Given this list of marker genes SFRP2, PCOLCE, MFAP4, IGFBP5, LHFPL6 (NCBI Gene Id 10186), MGP, GPC3, PI15, IL11RA, MEOX2, RCN3, ITM2A, FLRT2, CDH9, RAB23, GPX7, LRRC17, PRAF2, RAMP2, CD248, CUEDC2, PLAC9, here is a description of the gene set: from publication Gao S, Yan L, Wang R, Li J, Yong J, Zhou X, Wei Y, Wu X, Wang X, Fan X, Yan J, Zhi X, Gao Y, Guo H, Jin X, Wang W, Mao Y, Wang F, Wen L, Fu W, Ge H, Qiao J, Tang F (PMID 29802404) species: Homo sapiens Human Gene Set: GAO_SMALL_INTESTINE_24W_C2_PROCRPOS_PROGENITOR